The following is a description of a gene set: studied in species Mus musculus The chemical reactions and pathways involving a pyrimidine ribonucleotide, a compound consisting of nucleoside (a pyrimidine base linked to a ribose sugar) esterified with a phosphate group at either the 3' or 5'-hydroxyl group of the sugar. Mouse Gene Set: GOBP_PYRIMIDINE_RIBONUCLEOTIDE_METABOLIC_PROCESS, and this is the list of marker genes: Ak9, Cda, Entpd7, Nme5, Nme7, Nme3, Nme4, Dck, Dpys, Nme6, Uckl1, Ctps2, Upp2, Uck2, Cmpk1, Nt5c, Entpd5, Nme1, Upb1, Ctps1, Upp1, Cad, Nt5c3, Ak3, Entpd4, Uprt, Umps, Uck1, Nme2, Entpd4b, Dpyd, Dhodh